Given this list of marker genes Alyreffm11, Tial1, Alyreffm10, Alyref, Hnrnpa2b1, Alyreffm8, Lin28a, Sh3bgrl, Qki, Ybx1, Alyreffm7, Fmr1, Ythdf2, Srsf3, Alyreffm9, Ythdc1, Hnrnpc, Alyreffm4, Ythdf1, Igf2bp2, Alyreffm6, Ythdf3, Dgcr8, Alyreffm3, Igf2bp1, Rbm33, Alyreffm1, Alyreffm5, Ythdc2, Zfp598, Igf2bp3, Alyref2, here is a description of the gene set: studied in species Mus musculus The binding activity of a protein that brings together another protein and an RNA, permitting those molecules to function in a coordinated way. Mouse Gene Set: GOMF_PROTEIN_RNA_ADAPTOR_ACTIVITY